The following is a description of a gene set: The component of mitochondrial inner membrane consisting of gene products and protein complexes that are loosely bound to one of its surfaces, but not integrated into the hydrophobic region. Human Gene Set: GOCC_EXTRINSIC_COMPONENT_OF_MITOCHONDRIAL_INNER_MEMBRANE studied in species Homo sapiens, and this is the list of marker genes: COQ6, COQ8A, COQ2, COQ5, COQ4 (NCBI Gene Id 51117), COQ7 (coenzyme Q7, hydroxylase), COQ3